Given this list of marker genes RHAG, SLC4A1, CA1, HBB, HBA1, CA4, CYB5R4, AQP1, CYB5R2, CYB5RL, CYB5R1, CA2, here is a description of the gene set: In capillaries of the lungs Erythrocytes take up oxygen and release carbon dioxide. In other tissues of the body the reverse reaction occurs: Erythrocytes take up carbon dioxide and release oxygen.<br>In the lungs, carbon dioxide (CO2) bound as carbamate to the N-terminus of hemoglobin (HbA) and protons bound to histidine residues in HbA are released as HbA binds oxygen (O2). Bicarbonate (HCO3-) present in plasma is taken up by erythrocytes via the band3 anion exchanger (AE1, SLC4A1) and combined with protons by carbonic anhydrases I and II (CA1, CA2) to yield water and CO2. The CO2 is passively transported out of the erythrocyte by AQP1 and RhAG. HCO3- in plasma is also directly dehydrated by extracellular carbonic anhydrase IV (CA4) present on endothelial cells lining the capillaries in the lung.<br>In non-pulmonary tissues CO2 in plasma is hydrated to yield protons and HCO3- by CA4 located on the apical plasma membranes of endothelial cells. Plasma CO2 is also taken up by erythrocytes via AQP1 and RhAG. Within erythrocytes CA1 and, predominantly, CA2 hydrate CO2 to yield HCO3- and protons. HCO3- is transferred out of the erythrocyte by the band 3 anion exchange protein (AE1, SLC4A1) which cotransports a chloride ion into the erythrocyte.<br>Also within the erythrocyte, CO2 combines with the N-terminal alpha amino groups of HbA to form carbamates while protons bind histidine residues in HbA. The net result is the Bohr effect, a conformational change in HbA that reduces its affinity for O2 and hence assists the delivery of O2 to tissues. part of: Transport of small molecules species: Homo sapiens Reactome Pathway: O2/CO2 exchange in erythrocytes